Given this list of marker genes Gm13974, Gm21596, Mir7002 (microRNA 7002), Gjd2, Arhgap11a, Gjd2os, 4930533B01Rik, Gm26505, Gm13964, Tmco5b, Gm13975, Mir1951, Cdin1, Actc1, 4930528P14Rik, Ryr3, 3110099E03Rik, Actc1dt, Scg5, Grem1, Fmn1, Zfp770 (zinc finger protein 770), Gm13963, Aqr, Dph6, here is a description of the gene set: Mouse Gene Set: chr2E4 studied in species Mus musculus